Given this list of marker genes ASB7, MAL2, WDPCP, CCND1, SLC25A17 (solute carrier family 25 member 17), EBF2, ALG13, RAB5B, NPVF, EN2, TRERF1, ZNF410, PELO, YRDC, IGF1R, SALL3, UBE2H, DDX17, PAX6, OSER1, COL13A1, PPP1R10, RGS3, LENG9, ATP2A3, NTS, DLX5, CYP26C1, MS4A5, HPCAL4, CHST7, ATP13A4, NTF3, BRINP3, ST8SIA1, NDP, KCNS3, DPYSL2, CADM2, DLG2, YIPF4, HTN1, ANKRD40, KRT26, TOB1, SCN2A, PAG1, USP18, HOXC4, ARNT, CTCF, SOX4, SPRED1, PDRG1, KAT6B, HCAR3, PDE4B, HOXD10, TLE4, PAK1IP1, KLF12, PRKACB, LMO7, CXCR4, ZFP42, CCDC85B, SLC20A1, RHOQ, GET4, LRP5, PDLIM3, SLC35C2, COX7B2, ITGA1, KCNJ16, BNC2, AP1G2, CNTN6, TFDP2, TLE3, KMT2E, PABIR1, EMX2, C8orf82, HEY1, CDC42EP3, BUB3, SCNN1G, NIN, EYA1, C12orf57, MRPS18B, TTN, MSL3, LGI1, EGR2, MIA2, SHKBP1, FGF12 (fibroblast growth factor 12), TSSK3, TBCC, CAST, NDST1, S100PBP, CELF2, ZBTB9, SOBP, WIPI1, PSMD3, PELI2, PCLAF, GPRC5B, PLN, ENPEP, MAP2, RALGPS2, UBE2S, LAMP5, HOXB2, FNBP1, LOX, GPC4, ZEB2, ALDOB, HOXB8, MRFAP1, IP6K2, FRY, ATXN1, ETV5, ZNF485, SUN5, PPFIA3, DNAJC10, ENSG00000291228, PCDH11X, ROBO1, SPEM1, SYT6, SPAG9, C1orf122, ABCB7, ZFYVE27, NTN5, UNC13D, AMD1, IKZF2, PCBP1, NKX2-1, TRIM8, OLFML3, RAB6C, AIFM1, TWIST1, SLCO3A1, FGF9, HIVEP3, KRT77, SPMIP6, NPTX2, KRT10, PHOX2B, HCAR2 (NCBI Gene Id 338442), GNPNAT1, ARG2, ASIC2, HOXC6, NRP1, RB1CC1, NEO1, HOXD12, PCF11, ZNF277, ARRDC3, TSGA13, CREB5, ESM1, GSX1, CYSLTR1, C19orf73, MACIR, CDYL (NCBI Gene Id 9425), HIVEP2, HOXA11 (homeobox A11), SYNRG, PRKAG1, MINK1, RIPK4, PRMT3, ARPP21, NEDD4 (NCBI Gene Id 4734), CHMP1B, CRB1, LRMDA, PUM2, CDH20, CDAN1, SLC39A12, PAX8, GRHL1, PPP2R2B, MAB21L2, TMCC1, C1orf116, CACNA1D, GBX2, MYO15A, PCDH11Y (protocadherin 11 Y-linked), SALL2, SLITRK2, GRM5, ARHGDIB, DHX32, CBX6, ERF, SPRY2, TFAP2B, CRIM1, HOXC11, LARP7, DSCAML1, CRYGD, FOXP1, TNR, ZNF423, PRICKLE2, FGF7, PTTG2, PURA, PRPS1L1, IL20, LUC7L3, ZFHX3, RSKR, ZPLD1, CSNK1E, DOCK4, GARRE1, DPP10, RIMS1, NFIX, NDFIP1 (Nedd4 family interacting protein 1), SUMO4, BOC, MOSMO, IGF1, ITGBL1, UBAP2L, DGKI, ZIC2, NCDN, RSPO2, USP32P2, PBX1, OTX1, ZNF407, TAF10, CADM1, SKIDA1 (NCBI Gene Id 730417), PTF1A, HMCN1, CCDC14, here is a description of the gene set: Human Gene Set: TEF_Q6 Genes having at least one occurrence of the motif ATGTTWAYATAA in the regions spanning 4 kb centered on their transcription starting sites. This matches the TEF transcription factor binding site V$TEF_Q6 (v7.4 TRANSFAC). species: Homo sapiens